Given this list of marker genes CPE, TBX5, RYR2 (ryanodine receptor 2), SFRP2, RBPJ, NPY2R, NOTCH1, HEY2, EVA1A, NAGLU, GSK3A, FOXF1, TGFBR2, HAND1, EDNRA, SMAD4, NPY5R, here is a description of the gene set: The process in which the left cardiac ventricle is generated and organized. Human Gene Set: GOBP_CARDIAC_LEFT_VENTRICLE_MORPHOGENESIS studied in species Homo sapiens